The following is a description of a gene set: electronically inferred by orthology from the curated human pathway This event has been computationally inferred from an event that has been demonstrated in another species.<p>The inference is based on the homology mapping from PANTHER. Briefly, reactions for which all involved PhysicalEntities (in input, output and catalyst) have a mapped orthologue/paralogue (for complexes at least 75% of components must have a mapping) are inferred to the other species. species: Mus musculus part of: Transmission across Chemical Synapses Reactome Pathway: Presynaptic depolarization and calcium channel opening, and this is the list of marker genes: Cacna2d2, Cacnb3, Cacnb1, Cacna1a, Cacng4, Cacna2d3